The following is a description of a gene set: species: Homo sapiens gene expression data from wild-type and Bcl6-/- regulatory T cells in order to find genes regulated by Bcl6 in Treg cells Genes up-regulated in T reg: BCL6 knockout versus wildtype. from publication Sawant DV, Sehra S, Nguyen ET, Jadhav R, Englert K, Shinnakasu R, Hangoc G, Broxmeyer HE, Nakayama T, Perumal NB, Kaplan MH, Dent AL (PMID 23053511) Human Gene Set: GSE40493_BCL6_KO_VS_WT_TREG_UP, and this is the list of marker genes: APPL1, UBA6, MICU2, PSMD7, IFT74, TSNAX, SIN3B, ARAP1, RABL2A, LARGE1, EZR, CFDP1, UROD, AGA, TSGA10, PCGF3, FGD3, PLS3, LMAN1, SH3KBP1, ERGIC3, MIR29A, KCTD21, UTP15, CASP8, PJA1, RAD50, FNBP1, TWSG1, USP45, PTK2B, MRPS5, USP40, TATDN3, RREB1, RPAP3, SMG1, TFG, TRRAP, ZDHHC5, EIF3A, NUDT2, DPH6, DDX31, SEL1L, SDF4, PTP4A2, TULP4 (TUB like protein 4), CTDP1, CDK8, ADAM10, MRPL45, CECR2, URGCP, RRP1B, ERI1, LPIN2, TTC27, SOS2, CEP170, CCT7, THOC5, PPT1, GNPDA2, CRBN, VPS13D, MIB1, SORT1, DYNC1H1, PRKAB1, SUPT6H, GOLIM4, PABPN1, SUFU, GOLGA5, GPKOW, AHCTF1, PSD3, ROCK2 (NCBI Gene Id 9475), DYNC2I1, TRIO, TUBB2A, PDE2A, HS2ST1, GTPBP8, GCLC, PKN2, ANGPTL1, NACC1, TPRKB, NCK1, FBXO11, SETDB1, PCMTD1, UCHL5, EFHC1, PHLPP1, GIMAP1, NOD2, CCDC9, RCOR1, GUF1, NLRP3, ANXA9, SLU7, GIPC1, ZYG11B, CHMP1B, FBXO38, DYNC1LI2, ZFC3H1, GLRA3, FOXO6, ARHGEF7, RFXAP, TNKS2 (NCBI Gene Id 94771), KATNAL1, USP9X, CUL1, COPS8, PJA2, AQR, PNPLA8, DNAJC11, NSUN2, PPID, PRPF6, EIF4B, TBC1D1, SAE1, NFXL1, GPS1, RALGAPA2, CCT3, PTPN11, RLIM, SAMD4B, PSMD4, NMT2, SEC11A (SEC11 homolog A, signal peptidase complex subunit), DLD, GOLGA3, ATXN3, ZWINT, HACE1, DDB1, CTPS2, URB2, COPB2, GFM1, N4BP2, GLG1, EXO5, DDX24, USP47, SERTAD3, NCOA6, GOLGA4 (golgin A4), UBE2Q1, TMF1, FADS1, MPHOSPH10, BOD1L1, RSPRY1, YME1L1, DDX54, SSH3, ECE1, ZC3H11A, EXTL3, DHRS7 (NCBI Gene Id 51635), HSPH1, CGNL1, VPS41, MRFAP1, OPA1, RWDD1